Given this list of marker genes NOXRED1, DTNA, AP1G1, ALPK3, CREB3L1, SEC24C, LARP4B, GLUL (glutamate-ammonia ligase), ATG2A (NCBI Gene Id 23130), KAT6A, MR1, PPP1R15B, FAM185A, VAPA, CDH5, CACNA1G, NUDC, MBD6, SRD5A3, GRIK1, CLCN6, GMEB1, SCN3B, DAZAP2, KDM6B, CFAP47, CDIN1, IRX6, SLC1A6, KRT76, NATD1, ZNF704, PTGDS, PXYLP1, ZNF532, DNAAF3, IRF6, CISD1, NOVA1, ITGB1BP1, EZH1, LSM12, MOB3B, AK2, SERPINB8, SLC16A2 (NCBI Gene Id 6567), LONRF2, CLCF1, MLLT10, RUFY4, HYAL3, ARFGEF3, KCNQ5, ZC4H2, SLC12A6, DNAJC5G, KIAA0040, SRMS, ELAVL2, KCNK3, RAB18, PYGM, ADGRE3 (adhesion G protein-coupled receptor E3), SC5D, GNG13, CAMK1D, EAF1, ARF3 (ADP ribosylation factor 3), FAM47E-STBD1, GEMIN2, DHRS3, SNX22, MMP25, FGFR2, CYP1B1, SENP3, APOBEC3H, ADRB3 (adrenoceptor beta 3), PSD2, FPR1, PITPNM2, ATOSB, PHYHIP, CD22, here is a description of the gene set: Genes predicted to be targets of miRBase v22 microRNA hsa-miR-4745-5p in miRDB v6.0 with MirTarget v4 prediction scores > 80 (high confidence targets). studied in species Homo sapiens Human Gene Set: MIR4745_5P from publication Chen Y, Wang X (PMID 31504780)